Given this list of marker genes UCK1, DCTD, DCK, CDA, UPP1, UPRT, UCK2 (NCBI Gene Id 7371), CMPK1, UPP2, CAD, SHMT1, TYMS, UMPS, DHODH, UCKL1, DUT, here is a description of the gene set: The chemical reactions and pathways resulting in the formation of pyrimidine nucleoside monophosphate, a compound consisting of a pyrimidine base linked to a ribose or deoxyribose sugar esterified with phosphate on the sugar. studied in species Homo sapiens Human Gene Set: GOBP_PYRIMIDINE_NUCLEOSIDE_MONOPHOSPHATE_BIOSYNTHETIC_PROCESS